The following is a description of a gene set: Binds to and modulates the activity of a peptidase, any enzyme that catalyzes the hydrolysis peptide bonds. Human Gene Set: GOMF_PEPTIDASE_REGULATOR_ACTIVITY species: Homo sapiens, and this is the list of marker genes: SPINK8, GPC3, SPOCK3, COL4A3, C4A, ANXA2 (annexin A2), CASP8AP2, HMSD, PSME2, MAL, COL6A3, NGF, RARRES1, SPINK13, CST4, CSTB, SLCO1B7, NRDC, APP, SNCA, CARD18, ITIH4, NLRP1, SMR3A, CST11, WFDC5, SERPINE1, PCOLCE2, SERPINB2, SERPINA5, SPINK7, PYCARD, TIFAB, XIAP, SERPINA9, PRNP (prion protein (Kanno blood group)), EPPIN, A2ML1, SERPINA6, VCP, GAPDH, SPINK9, NLRC4, SERPINB1, SPP2, PSMF1, SPOCK1, WFDC10A, APAF1, CASP1, SERPINE2, ANOS1, NLRP12, TGFB1, SPINT1, SERPINB6, COL7A1, PINK1, SERPINB9, WFDC6, PSME3, C5, GBP2, ITIH5, CST9LP1, VSIR, TFPI2, APLP2, UCHL5, NCSTN, SERPINI1, SERPINI2, ATP2A3, LGMN, NKX3-1, BIRC5, RENBP, WFDC1, SERPINA1, SERPINA2, SERPINE3, TIMP3, SERPINB4 (serpin family B member 4), SERPINA7, TIMP4, SPINK5, WFIKKN2, SLCO1B3-SLCO1B7, PCOLCE, SFRP2, CST3 (NCBI Gene Id 1471), WFIKKN1, CST8 (cystatin 8), COL28A1, CSTL1, BAD, HSPD1, FBLN1, PI16, C3 (NCBI Gene Id 12266), SERPINB12, OPRPN, NLRP7, CTSC, FN1, APH1B, CRIM1, CSTA, CD109, ROCK2, ADRM1, CST2, SSPOP, CST7, WFDC8, WFDC11, SERPINA10, SVBP, ITIH3, SPINK4, WFDC12, SERPINA12, CAST, CST6, BIN1, PRSS22, SERPINB13, TFPI (tissue factor pathway inhibitor), CSN2, SPINT4, LTF, CARD16, BEX3, UMODL1, BST2, PZP, CLPX, LPA, WDR48, R3HDML, USP14, SLCO1B3, SPINK1, WFDC9, MAPK12, THBS1, NAIP, PAPLN, A2M, WFDC13, DMWD, SERPIND1, PTTG1, TANK, PI3, CST9, SPINK6, C4B, GBP5, SERPINB7, SLPI, SERPINH1, HRG, CTSH, SPINK2 (serine peptidase inhibitor Kazal type 2), WFDC3, APH1A, BCL2L13, NLRP3, SERPINB5, AIM2, NOD1, SIMC1, ITIH2, SPINT3, PSMD14, RECK, ST20 (NCBI Gene Id 400410), PSME4, SORL1, RACK1, SERPINA4, SMR3B, CPAMD8, CAV1, PI15, PARK7, MANSC4, SPOCK2, ABCA2, WDR20, SERPINB11, SERPINF2, PSENEN, TIMP1, LXN (NCBI Gene Id 56925), BIRC6, SERPINA11, PROS1, SERPINB8, FURIN, PSME1, BIRC7 (baculoviral IAP repeat containing 7), SERPING1, PEBP1, AGT, KNG1, NDUFA13, AHSG, SPINK14, EBAG9, CST1, MALT1, SERPINF1, PCSK1N, CST5, ITIH6, SERPINB10, TIMM50, CST9L, SPINT2, LCN1 (lipocalin 1), SERPINA3, CARD17P, CRB2, WFDC2, SERPINC1, WFDC10B, TIMP2, SERPINB3, C3P1, ITIH1, AMBP, CARD8, FETUB